Given this list of marker genes DDB1, CDK8, DACT1, RNF43, LTBP4, JAK3, CCNQ, SEC24C, COL5A1, ITGB2, MLXIPL, TYMS, UFD1, AKT1, PMS2, PIGN, PDE11A, NHP2, HIRA, PIK3CA, BMPR1A, TCOF1, FREM2, SEC23B, MDM2, TTC7A, GRIP1, NOP10, GSTM3, SLC6A14, PIGV, GREM1, HFE, PI4KA (NCBI Gene Id 5297), DKC1, NAA10, MLH1, NCF1, KEAP1, SLC9A3, RPS20, TP53, UBR1, BUD23, KMT2D, LONP1, ARVCF, MID1, USB1, ENG, EIF4H, MSH2, KIT, BRCA2, NTHL1, NDUFB11, DOCK2, TERT, NCF2, VPS37D, MSH6, RAC2, CDKN2A, TERC, HOXD13, BAZ1B, CYBA, EFEMP1, SDHD, GTF2IRD1, PDGFRA, COL5A2, SDHA, COX7B, CHN1, SPINT2, SMAD4, RECQL4, ELN, METTL27, PARN, POLR1C, NSUN2, SRP68, STK11, SLC11A1, HCCS, KDM6A, COL1A1, IL10RB (NCBI Gene Id 3588), SDHB, POLR1B, GP1BB, IGHM, KLLN, DICER1, POLD1, FREM1, RFC2, ATM, AXIN2, HMOX1, GTF2I, CTC1, INSR, BCOR, FCGR2A, PRMT7, MSH3, RREB1, MNX1, STX1A, POLR1D, RTEL1, APC, CFTR, MUTYH, VANGL1, NBN, CLCA4, CYBB, TCTN3, TINF2, KRAS, CEACAM6, TBX1, SLC26A9, MKKS, NPM1, RAD51C, EPCAM, TMEM270, MAFB, ZFX, CCBE1, PMS1, DNAJC30, LMNA, OTUD5, CLIP2, POLE, RPS6KA3, TGFBR2 (NCBI Gene Id 7048), GCLC, DYM, MYH11, SEMA4A, MIF, LIMK1, FRAS1, SALL1, EDNRA, COMT, KIF7, CEACAM3, TGFB1, TBL2, PTEN, SALL4, LIG4, DCTN4, WRAP53, KCNN4, USF3 (upstream transcription factor family member 3), JMJD1C, STAT3, RNU12, PRKAR1A (NCBI Gene Id 5573), SDHC, SERPINA1, FKBP6, CHEK2, GTF2IRD2, here is a description of the gene set: Anorectal anomaly species: Homo sapiens Human Gene Set: HP_ANORECTAL_ANOMALY An abnormality of the anus or rectum.